The following is a description of a gene set: species: Mus musculus Mouse Gene Set: GOBP_URETERIC_BUD_FORMATION The developmental process pertaining to the initial formation of the ureteric bud from the Wolffian duct. This process begins when the bud protrudes from the duct and ends when it is a recognizable bud., and this is the list of marker genes: Six1, Hs2st1, Grem1, Gdnf, Six4, Gata3, Nog